Given this list of marker genes FAM20B, ZNF135, UGT2A3 (NCBI Gene Id 79799), CARMIL1, PTPRK, PKM, SLC6A6, ABHD3, SEZ6, CLEC16A, MPI, SYK, FAM193A (family with sequence similarity 193 member A), GALNT4, PLAAT2 (phospholipase A and acyltransferase 2), NEK6 (NCBI Gene Id 58167), PDE3A, ATXN7, NFIA, DCAF7, TFAP2A, KPNA6, AGO2, PPFIA1, STX1A, BCORL1, CABYR, SLITRK3 (SLIT and NTRK like family member 3), STON2, DPYSL3, MSI1, PLCG1, KIAA1549, ITPK1, PPP1R12B, ZNF335, B3GAT1, DCSTAMP, MMP24, CD99L2, POC1B-GALNT4, CBLN3, HIP1R, HELZ2, ACER3, ARFIP2, STIM2, IGFBP5, SLC9A8, BACH1, SGTA, COL24A1, RAB43, HECTD1, MOCS3, FAM216B, RREB1, CSGALNACT1, TBC1D10C, RAPGEF5, SNN, PTPRT, MLEC, THRB, SLU7, BCL2L11, CHRM1, EPHB2, PURA (NCBI Gene Id 5813), LCOR, CMTM4, ROBO1, TPRG1L, SELENON, PCSK2 (NCBI Gene Id 5126), LIMK2, SRGAP2 (SLIT-ROBO Rho GTPase activating protein 2), NDUFC1, CCND1, PTPN1, MINDY3, VPS26C, HIPK1, MAPK6, ARMC1, GALNTL6, RAP1B, ADCY1, TMEM151B, PXN, DUT, SLC25A16, P3R3URF-PIK3R3, TAS1R3, PIK3R3, FOXN2, WIPI2, SRPK1, OXSR1, EPHA8, C17orf100, PHF21A (NCBI Gene Id 51317), ACOT11, CHP1, DLG5, HIPK2, ALKBH3, IQCE, KCTD4, GPD1L, FAM124A, RAB30, ZNF219, TMEM72, CDC23, STAC, KCNH7, here is a description of the gene set: species: Homo sapiens Human Gene Set: MIR5580_5P Genes predicted to be targets of miRBase v22 microRNA hsa-miR-5580-5p in miRDB v6.0 with MirTarget v4 prediction scores > 80 (high confidence targets). from publication Chen Y, Wang X (PMID 31504780)